Given this list of marker genes ACTN4, ATP1B2, FGF13, STK39, WNK3, FXYD3, FXYD1, WNK2, TESC, FXYD4, SCN1B, FXYD6P3, FXYD7, FXYD2, ATP1B3 (ATPase Na+/K+ transporting subunit beta 3, NCBI Gene Id 483), CHP1, ATP1B1, FXYD5, NOS1, FXYD6, here is a description of the gene set: Any process that activates or increases the frequency, rate or extent of sodium ion transmembrane transport. Human Gene Set: GOBP_POSITIVE_REGULATION_OF_SODIUM_ION_TRANSMEMBRANE_TRANSPORT species: Homo sapiens